The following is a description of a gene set: The presence of autoantibodies in the serum that react against extractable nuclear components that are referred to as extractable because they can be extracted from cell nuclei with saline solution. Extractable nuclear antigen positivity studied in species Homo sapiens Human Gene Set: HP_EXTRACTABLE_NUCLEAR_ANTIGEN_POSITIVITY, and this is the list of marker genes: C4B, SPP1, DNASE1, KIAA0319L, HLA-DRB1, CTLA4, PDCD1, BANK1, TLR7, C4A, STAT4, IRF5, TNFAIP3, BLK, IGHG1, PXK, FCGR3B, ETS1 (ETS proto-oncogene 1, transcription factor), MECP2, IL10, UBE2L3, IRAK1, PTPN22, FCGR2B, TNFSF4, DOCK11, TNIP1, TREX1, C1QB, ITGAM, JAZF1, LYN, CR2, SOCS1